The following is a description of a gene set: Human Gene Set: GOBP_COMPLEMENT_ACTIVATION studied in species Homo sapiens Any process involved in the activation of any of the steps of the complement cascade, which allows for the direct killing of microbes, the disposal of immune complexes, and the regulation of other immune processes; the initial steps of complement activation involve one of three pathways, the classical pathway, the alternative pathway, and the lectin pathway, all of which lead to the terminal complement pathway., and this is the list of marker genes: MASP2, MIR520B, IGHG4, CLU, C1QC, CFHR3, FCN3, C3, IL1B, C1S, C1R, C6, C7, C4B, MASP1, C8B, IGHA1, CD55, C1RL, CR2, SERPING1, CD46, VSIG4, IGHA2, CFP, CFH, IGHG2, IGHE, C8A, IGHD, COLEC11, IGHG3, CFHR5, CR1L, C1QA (NCBI Gene Id 712), MIR520E, PHB2 (prohibitin 2), C4BPA, COLEC10 (collectin subfamily member 10), MBL2, A2M, C5, SUSD4, FCN2, CFHR2, CD59, C4BPB, CFI, C8G, IGHG1, CFHR4, C1QB, PHB1, KRT1, CFD, CR1 (NCBI Gene Id 1378), CFHR1, C4A, FCN1, CFB, TREM2, C2, CD5L (NCBI Gene Id 93016), C9, C1QBP